The following is a description of a gene set: A protein complex first characterized in human and comprised of a R2TP module (R2TP complex), a prefoldin-like module (containing both prefoldin-like proteins and canonical prefoldins), WD40 repeat protein Monad/WDR92 and DNA-dependent RNA polymerase subunit RPB5. This complex might have chaperone activity. Mouse Gene Set: GOCC_RPAP3_R2TP_PREFOLDIN_LIKE_COMPLEX studied in species Mus musculus, and this is the list of marker genes: Pfdn6 (NCBI Gene Id 14976), Ruvbl1, Rpap3, Pfdn2, Uxt, Polr2e, Ruvbl2, Dnaaf10, Pdrg1, Uri1, Pih1d1